Given this list of marker genes IGSF3, CLN8, TMEM87A, BRCC3, PLGRKT, DNM1L, ALDH9A1, ALDH3A2, AGK, TMEM126B, RPS20, RAD51C, PAICS, CCDC88A (NCBI Gene Id 731560), APEH, NOC2L, ACVR2A, PDE4A, PALB2, GPR15, TEX2, DNAJC2, KEAP1, ARHGAP22, TMEM176B, UTP14A, SLC35A3, DERA, PAAF1, FABP5, FAIM2, NSUN3, LPIN1, SRD5A3 (steroid 5 alpha-reductase 3), PGD, DARS1, RMND1, ATP1B1, SLC35D1, RAB38, C11orf24, DAP3, NNT, PTBP1, GPATCH1, SEC11A, TPRKB, RPL10A (NCBI Gene Id 4736), MT1X, SPHK2, EIF2S2, ARB2A, DUSP7, SMARCE1, MICAL3, FAM149B1, UNC119B, RUFY3, NUP133, SLC31A2, FILIP1L, CDC23, ALDH5A1, AGPAT4, MCCC2, LIPA, COPB2, ARL1, TCF4, USP14, TACSTD2, EAF2, PECR, NSDHL (NCBI Gene Id 50814), PTCD1, SUGP1, CILK1, SLFN12, STAG1, TUBG1, CEP83 (centrosomal protein 83), NDUFV2, TRIAP1, RPL35, CD99, GOT2, PJA1, FDX1, TTLL1, GALNT12, WIF1, ENO2, OAS1, MAGT1, SKIC8, DNASE2B, MRPS11, GORASP2, NIF3L1, PRKY, FAHD2A, ABCC3, WDR43, TTC31, RPL26L1, ATOX1, PANK2, PDHB (pyruvate dehydrogenase E1 subunit beta), SLC25A17, COL6A1, ADGRB1, IRF8, EFL1, AKR7A3 (aldo-keto reductase family 7 member A3), COQ4, MRPL15, COPZ1, ZFP69B, MKKS, RRAGA, TRAC, SMARCAL1, PIPOX, TRIP6, BSCL2, AQP3, TSR3, MREG, SERPINE1, BMAL2, TRIP4, IL3RA, CLSTN1, ATXN10, INVS, ABCC1, RBMS2, RPL7, GOLGA8B, PDSS1, LILRB4, MLH1, COX5A, CCL17, IFI27, ACAT1, UTP14C, PPP1R7, HARS1, PPP3CB, THAP3, MAPKAPK5, MATK, ACBD3 (NCBI Gene Id 64746), APEX1 (apurinic/apyrimidinic endodeoxyribonuclease 1), COG7 (NCBI Gene Id 91949), KDM4C, PDCD6IP, PRDM4, ATP5MC2, VTN, PRPS2, PAPOLA, VANGL1, DDO, NDUFC2, TOR3A, TAF9 (TATA-box binding protein associated factor 9), ZNF22, CIAO1 (cytosolic iron-sulfur assembly component 1), CXCL10, MAIP1, ACP1, SHQ1, EXOSC10, PTER, SNRNP27, MPDU1, CKAP5, PRKAR2B, HMGN5, MRPL35, GTF3C3, RIOX1, RPL21, NUP107, NDUFAF1, IGFLR1, CCND1, ATP5IF1 (NCBI Gene Id 93974), NDUFS8, HSD11B1, ELAVL1, LDHB, ADORA2B, MRPL39, PLAG1, MELK, MRFAP1L1, here is a description of the gene set: Genes up-regulated in comparison of dendritic cells (DC) stimulated with LPS (TLR4 agonist) at 48 h versus neutrophils stimulated with LPS (TLR4 agonist) at 1 h. In the present study we used Affymetrix oligonucleotide microarrays to produce gene transcription profiles for the major leukocyte types in humans. This comprehensive dataset enabled us to not only establish which genes were expressed in each leukocyte type, but also which genes were expressed in each subset after activation. The used of a comprehensive dataset of gene profiles from all the major human leukocyte subsets enabled a novel and powerful means for identification of genes associated with single leukocyte subsets, or different immune paradigms. Human Gene Set: GSE3982_DC_VS_NEUTROPHIL_LPS_STIM_UP studied in species Homo sapiens from publication Jeffrey KL, Brummer T, Rolph MS, Liu SM, Callejas NA, Grumont RJ, Gillieron C, Mackay F, Grey S, Camps M, Rommel C, Gerondakis SD, Mackay CR (PMID 16474395)